Given this list of marker genes Tas1r3, Mmp1b, Ermn, Dgcr2, Pira12, Ammecr1 (AMMECR nuclear protein 1), Nrsn2, Scai, Dazl, Gm5938, Pakap, Fras1, Pafah1b1, Lifr, Rbm27, Emc4, Brpf1, Zbtb2, Fzd7, Zfp663, Nexmif, Ubxn2a, Serpinb9c, Hs1bp3, Deptor, Asz1, Arhgap15, Pyroxd2, Cenpo, Prorsd1, Taok3, Abcf3, Rab27b, Ranbp3l (NCBI Gene Id 223332), Stam, Rel, Txnrd1, P2rx4, Bmyc, Sirt1, Zfp869, Tacc1, Sftpa1, Cyrib, Gabrb2, Anxa4, Rabep1, Tmsb15b1, Tsc22d1, Ap1ar, Map2, Pom121l2, Exoc3, Gria2, Casp12, Efl1, Cep170, Cacnb4, Alx1, Ror1, Zdhhc3, Myo6, Fbxl20, Pld5, Mdga2, Prrc2b, Slc4a7, Mat1a, Eif3a, Bahcc1, Cers6, Acot11, Hikeshi, Tceal7, Cxadr, Ednrb, Mastl, Oxsm, Tbcel, Prl2c3, Cgnl1, Cmklr2, Cep350 (NCBI Gene Id 74081), Fbxo32, Igf1r, Chmp2b, Nat1, Ncbp3, Atad1, Ppme1, Rbms3, Zfp281, Rag2, Rngtt, Lox, Tmprss11f, Spin4, Snx27, Gpr174, Gtf2i, Atad2b (ATPase family, AAA domain containing 2B), Tmem167, Ripor2, Rpp25, Aff4, Rnf17, Serpinb3a, Cd200r3, Scn2a (NCBI Gene Id 241424), Mbtd1, Cyb5b, Ywhah, Pira2, 4930426D05Rik, Rfesd, Ttll7, Kcnh5 (NCBI Gene Id 238271), Emc1 (NCBI Gene Id 72557), Ptprc, Relch, Tcp1, Mef2a, Rps6ka6, Gpr158, Ncam2, Dzip1l, Shq1, Prl2c2 (NCBI Gene Id 18811), Col10a1, Gria3, Tmem168, Igf1, Tmem68, Ppm1e, Ttn, Usp43, Srsf7, Wwp1, Rab9b, Ints15, Akap11, Elmo2, Efhc1, Hoga1, Fam120a, Ino80d, Ccng1, Tada1, Tnfsf10, Plpp3, Cpne1, here is a description of the gene set: Mouse Gene Set: MIR_488_3P from publication Chen Y, Wang X (PMID 31504780) studied in species Mus musculus Genes predicted to be targets of miRBase v22 microRNA mmu_miR_488_3p in miRDB v6.0 with MirTarget v4 prediction scores > 80 (high confidence targets).